The following is a description of a gene set: The chemical reactions and pathways involving S-adenosylhomocysteine; the L-enantiomer is formed from S-adenosylmethionine and is a strong inhibitor of S-adenosylmethionine-mediated methylation reactions. It can be cleaved to form adenosine and homocysteine. Mouse Gene Set: GOBP_S_ADENOSYLHOMOCYSTEINE_METABOLIC_PROCESS studied in species Mus musculus, and this is the list of marker genes: Pemt, Ahcyl, Ahcy, Gamt, Gnmt, Pcmt1, Icmt